Given this list of marker genes OTX2, POU3F1, ZNF521, WNT3A, SOX2, TBX6, ZEB2, FGF8, SOX1, GBX2, here is a description of the gene set: Human Gene Set: REACTOME_FORMATION_OF_THE_POSTERIOR_NEURAL_PLATE Formation of the posterior neural plate species: Homo sapiens